The following is a description of a gene set: Human Gene Set: ZHONG_PFC_MAJOR_TYPES_EXCITATORY_NEURON from publication Zhong S, Zhang S, Fan X, Wu Q, Yan L, Dong J, Zhang H, Li L, Sun L, Pan N, Xu X, Tang F, Zhang J, Qiao J, Wang X (PMID 29539641) studied in species Homo sapiens, and this is the list of marker genes: SLA, PPP2R2B, NEUROD6, RBFOX1, IGFBPL1, NEUROD1, CSRP2, NEUROD2